Given this list of marker genes COL6A1, SIX4, PPIF, KLHL40, NLN, RBM24, FKTN, CYP26B1, LARGE1, SHH, B4GALNT2, TBX1, FKRP, here is a description of the gene set: species: Homo sapiens The process in which a relatively unspecialized cell acquires specialized features of a skeletal muscle fiber cell. Skeletal muscle fiber differentiation starts with myoblast fusion and the appearance of specific cell markers (this is the cell development step). Then individual skeletal muscle fibers fuse to form bigger myotubes and start to contract. Human Gene Set: GOBP_SKELETAL_MUSCLE_FIBER_DIFFERENTIATION